Given this list of marker genes RBM8A, RPS8, UPF3A (NCBI Gene Id 95832), RPL3L, RPS27, RPS20, RPL15, RPS11, RPL6, UPF1, RPL7, RPS26, RPL12, RPL3, RPL26 (ribosomal protein L26), RPL39, RPL4, RPL8, RPL17, RPL32, RPS24, RPL7A, RPS27L, RPL19, RPS12, RPS27A, MAGOH, SMG1, RPS16, RPL26L1, RPS29 (ribosomal protein S29), RPS4Y2, RPL35A, 5S rRNA, RPL36A, RPL37, RPLP0, RPL27, GSPT1, 5.8S rRNA, FAU, RPL9, EIF4A3, RPL23, RPS17, RPL36AL, RPL36 (ribosomal protein L36), SMG6, UPF2, RPL13, UPF3B, RPS15A, RPL39L, RPS7, RPL11, CASC3, 28S rRNA, PPP2CA, GSPT2, RPL35, RPS6, PABPC1, RPS19, RPL34, MAGOHB, RPS14, EIF4G1, RPL29, RPS9, PNRC2, RPL28, RPL38, RPL22L1, NCBP2, RPS3, RPS2, RPL10L, RPS4Y1, RPS21, 18S rRNA, ETF1, RPS4X, SMG7, SMG9, PPP2R1A, RPS18, RPS25, RPL27A, RPL18A, RPL14, RPL23A, RPL21, RPSA, PPP2R2A, RPL41 (NCBI Gene Id 6171), RPL10A, RPL5, RPS3A, UBA52, RPL22, DCP1A, RPL10, SMG5 (SMG5 nonsense mediated mRNA decay factor), RPL18, NCBP1, RPL31, RPS5, RPL24, RPS13, SMG8, RPS23, RNPS1, RPLP2, RPS15, RPL30, RPS28 (NCBI Gene Id 6234), RPL13A (NCBI Gene Id 94020), RPLP1, RPL37A, RPS10, here is a description of the gene set: Reactome Pathway: Nonsense-Mediated Decay (NMD) part of: Metabolism of RNA species: Homo sapiens The Nonsense-Mediated Decay (NMD) pathway activates the destruction of mRNAs containing premature termination codons (PTCs). In mammalian cells a termination codon can be recognized as premature if it precedes an exon-exon junction by at least 50-55 nucleotides or if it is followed by an abnormal 3' untranslated region (UTR). While length of the UTR may play a part, the qualifications for being "abnormal" have not been fully elucidated. Also, some termination codons preceding exon junctions are not degraded by NMD so the criteria for triggering NMD are not yet fully known. While about 30% of disease-associated mutations in humans activate NMD, about 10% of normal human transcripts are also degraded by NMD. Thus NMD is a normal physiological process controlling mRNA stability in unmutated cells.<br>Exon junction complexes (EJCs) are deposited on an mRNA during splicing in the nucleus and are displaced by ribosomes during the first round of translation. When a ribosome terminates translation the A site encounters the termination codon and the eRF1 factor enters the empty A site and recruits eRF3. Normally, eRF1 cleaves the translated polypeptide from the tRNA in the P site and eRF3 interacts with Polyadenylate-binding protein (PABP) bound to the polyadenylated tail of the mRNA.<br>During activation of NMD eRF3 interacts with UPF1 which is contained in a complex with SMG1, SMG8, and SMG9. NMD can arbitrarily be divided into EJC-enhanced and EJC-independent pathways. In EJC-enhanced NMD, an exon junction is located downstream of the PTC and the EJC remains on the mRNA after termination of the pioneer round of translation. The core EJC is associated with UPF2 and UPF3, which interact with UPF1 and stimulate NMD. Once bound near the PTC, UPF1 is phosphorylated by SMG1. The phosphorylation is the rate-limiting step in NMD and causes UPF1 to recruit either SMG6, which is an endoribonuclease, or SMG5 and SMG7, which recruit ribonucleases. SMG6 and SMG5:SMG7 recruit phosphatase PP2A to dephosphorylate UPF1 and allow further rounds of degradation. How EJC-independent NMD is activated remains enigmatic but may involve competition between PABP and UPF1 for eRF3.